The following is a description of a gene set: from publication Lee MS, Hanspers K, Barker CS, Korn AP, McCune JM (PMID 15210650) Genes up-regulated in comparison of CD4 thymocytes versus thymic stromal cells. Human Gene Set: GSE1460_CD4_THYMOCYTE_VS_THYMIC_STROMAL_CELL_UP studied in species Homo sapiens Subpopulations of human fetal thymocyte and circulating naïve T cells were obtained through FACS sorting, including CD3-CD4+CD8- intrathymic T progenitor cells (ITTP), CD3intCD4+CD8+ \double positive\ thymocytes (DP), CD3highCD4+CD8- \single positive\ thymocytes (SP4), CD3+CD4+CD8-CD45RA+CD62L+ naive T cells from cord blood (CB4+), and CD3+CD4+CD8-CD45RA+CD62L+ naive T cells from adult blood (AB4+)., and this is the list of marker genes: PTDSS1, CSGALNACT1, CCND3, SPG11, SP140L, WNT16, SOX12 (NCBI Gene Id 6666), CAMK1D, NDNF (NCBI Gene Id 79625), STN1, RPS23, NHERF1, MTF2, GIMAP5, NR5A2, ZNF271P, OSBPL8, VGLL1, NOP53, KIF17, SDR39U1, APBA3, CUL1, AATF, FBXO46, POLH, TRIM14, GJC2, PLEKHG6, UCKL1, PCDHB13, NDUFV1, PDE4C, ACSBG1, VTCN1, RFC1, ARNT, DUSP2, ATP6V0A4, EPB42 (erythrocyte membrane protein band 4.2), C11orf71, PSMF1, MLLT3, MED9, VPS16, TRAPPC9, ATP6V0E2, NDE1, SERPINB1, MAP4K1, SDK2, ZNF692, CERK, SNX11, IL21R, PIK3CD, ASXL1, ARHGAP4, TNFSF10, MCM3AP, CELSR2, XRCC3, PIK3C2B, ZNF148, MSH2, IFI44L, ATG2A, BRD9, CBFB, XRCC2, HIC2, TAF1C, PPP2R2A, DCAKD, PCYOX1L, ZNF862, CRYBG1, GVINP1 (NCBI Gene Id 80073), FHIP2B (FHF complex subunit HOOK interacting protein 2B), VGLL4, ABCC2, DNAJC16, LIAS, LTA, LILRA4, PYHIN1, CLPS, ARIH2, KLF2, SCGB1A1, LINC00623, NMU (neuromedin U), WDR33, TFF3, PIWIL2, DGKA, CD72, FAAP24, PLIN1, ERC1, GATD3, MSI1, UBOX5, FMNL1, IL17RA, CD38, ERICH1, MAP2K6, RUNX3, NPAP1, TAPBPL, XPA, DIAPH1, LRIG2, PLEC, ZNF544, VAV3, STAT6, SUPV3L1, FBXO11, ZNF276, SEPHS2, SPN, TRANK1, TMEM50A, RAD9A, RAI1, GUSBP14, DCP2, NCOA1, ANAPC5, IKZF1, CPNE6, SND1-IT1 (NCBI Gene Id 92498), PTMA, BAG5, SPSB3, FLI1, POMC, TM7SF2 (transmembrane 7 superfamily member 2), TNF, REX1BD, ECEL1, ALMS1, PPWD1, SHANK1, CYP3A4, POLR2A, TMEM223, NGLY1, GATA3, DOLPP1, LRRFIP1, HMCES, INPP5D, TMEM131L, ZNF512B, SAFB, NFX1, ZNF652 (NCBI Gene Id 22834), CEP104, UBE2G2, RIMS3, CFAP46, STARD3, NDRG2, TUG1, CHAT, CD1E, ZNF778, FAM66D, IRF5, ACRV1, CASZ1, COQ8A, PLAC8, SNRNP200, CDK5RAP1, TAOK1, SIRT7, NUP88, SFPQ, DHX9-AS1, SGSM2, SASH3, POU2F1, ISG20, AGER, CHN2, PLLP, PRKAB1, TGIF2, AQP8, SIGLEC15, MFNG, RNF19A, LGI2, RSRP1, RNF34